The following is a description of a gene set: studied in species Homo sapiens Human Gene Set: GOMF_POLYAMINE_TRANSMEMBRANE_TRANSPORTER_ACTIVITY Enables the transfer of polyamines, organic compounds containing two or more amino groups, from one side of a membrane to the other., and this is the list of marker genes: SLC22A3, SLC18B1, SLC22A16, SLC22A2, ATP13A3, SLC47A1, SLC22A1, ATP13A2, ATP13A4, ATP13A5